The following is a description of a gene set: Human Gene Set: MODULE_13 species: Homo sapiens Genes in the cancer module 12., and this is the list of marker genes: TLE3, NPAS1, TMSB4Y, FHIT, ADGRE1, PAX8, ODF1, PPP2R5D, MEF2D, SYNCRIP, KAT7, SIM2, FMO4, M6PR, ALPG, MYOZ3, CIZ1, LYPD3, UNC119B, SLIT3, LPAR2, MAG (myelin associated glycoprotein), TCOF1, S100A5, SNX21, SLC4A3, SEMA3F, ADD2, KRT4 (keratin 4), VCY, FIG4 (FIG4 phosphoinositide 5-phosphatase), FEZ1, REL, PFDN1 (NCBI Gene Id 5201), SPC25 (SPC25 component of NDC80 kinetochore complex), IVD, DNALI1, MSC (NCBI Gene Id 9242), MMP15, ALAS2, ZBED4, KRT86, SKI, LLGL2, VASH1, DDX19A, EFNA3, AIF1, PPP6R2, MYOG, STXBP1, FBN2, DBN1 (NCBI Gene Id 1627), VPS9D1, CORT, KCNH2 (potassium voltage-gated channel subfamily H member 2), CD5L, IFIT1, RANBP2, SPEF1, UGT2B15, TBXA2R, RTN2 (NCBI Gene Id 6253), HSF4, ARC, SPART, ALDH1L1, MGP, PSD4, LAIR1, DRD3, RHBDL1, LY6G6C, RECQL5, HTR6, SRCAP, ACKR1, CSRP3, LTK, CDKN2C, CNTN2, IKBKE, LILRA4, ECE2, PDPK1, P2RX7, CLCNKA, HRG, JAG1, VSIG4, ZNF22, CD34, EMID1, PINK1, EXD2, CEP135, RPS6KB2 (NCBI Gene Id 9017), ASIC2, PTGS1, SLC13A2, INPP5D, SLC7A4, PSD, TNFRSF10C, SLC6A8, TEX261, XDH, CLIP2, DOK2, AVPR1B, TGOLN2, GRM4 (glutamate metabotropic receptor 4), USP9X, ANK1, KRT85, SIX1, CD19, SCAMP5, STARD5, PPP3CC, CYP2A6, TAFAZZIN, SH3BP1, GATA1, GAGE1, ABCC8, PDE4C, ORC1, CD33, SEMA4D, PRSS16, GTF2H3, SYNGR4, CD40, BUD23, ARHGAP4, YPEL1, B4GALT3, ETV3, KCTD17, NTSR2, AQP7, GFPT2, ZKSCAN7, CLEC11A, CYP11A1, SLC25A11, PICK1, FZR1, SLC18A3, KCND3, IFRD2, REG1A, MYO9B, GPA33, CTSC, LARGE1, NDST1 (NCBI Gene Id 3340), GPRIN2, CHRNB1, ACACA, CNKSR1, GPR161, ATP4A, AANAT, RAB8A, CCL13, IVL, FANCG, ADAM15, FUT7, RIBC2, ARSL, TRIM15, CD82, U2AF2, MDC1, ASGR2, ATP6V1B1, S1PR2, DGKA, KRT31, PLAU, TCF7, AMELX (amelogenin X-linked), LMO1, COL10A1, LRRC23, PLIN1, DEFA1, CARD10, ABHD14A, HSD11B2, SCARB1 (NCBI Gene Id 949), FLT1, SLC2A1, MXRA8, ACIN1, PSG7, IKBKG, CAD, SPRR2C, BMP10, DPT, PROC, DAPK2, TIMP3, SLC29A2, ELAVL2, ESR1, DOLK, TGFB1, MAGEA9, CRHR2, COPS6, CNOT4, HTR7, MGAT1 (alpha-1,3-mannosyl-glycoprotein 2-beta-N-acetylglucosaminyltransferase), CDK5R1 (cyclin dependent kinase 5 regulatory subunit 1), FCGR2A, CYP2C9, EFNB1, GHITM (growth hormone inducible transmembrane protein), TERF2, SULT4A1, CDK5R2, RASSF7 (Ras association domain family member 7), RAP1GAP, TUBB2A, METTL1, LGALS9, LSM4, GOLGA1, PAK4, IFT140, FOSL2, COL1A1, MYEF2, SLC5A2, BMP1, ADAMTSL2, ILRUN, RAC2, ITGA3, TM4SF5, SLC6A6, WBP4, LRCH4, KCNA5, ARVCF, C8B, SERBP1, ITSN1, CSF1, CTSG, DNAJC7, MMP11, PNMT, SIK3, TBX19, HTRA2, PLIN3, DIDO1, ARID4B, VAMP1, LY6E, TTLL12, EDEM1, CNTN1, KIF1C, UTRN (utrophin), ZSCAN12, SAC3D1, ESPL1, GLE1, HDGF, TEX28, CHST15, ANKRD12, ZNF157, ADCYAP1, ST6GALNAC4 (NCBI Gene Id 27090), RPS26, RGS9, ACKR2, GRIK5, DKK4, KCNJ4 (potassium inwardly rectifying channel subfamily J member 4), RIMS2, WNT10B, EPAS1, NEURL1, MYBPC1, LIF, LMTK2, PTPRO, CMA1, DMBT1, UCN, CHRNE, CD8B, PPM1D (NCBI Gene Id 8493), BAHD1, ASCC2, FGFR4, ITGA10, IRF5, ZBTB40, CCKAR, PBX1, ASGR1, CREBZF, LRIT1, DNAH9, CDH16, LYZL6 (lysozyme like 6), TNP1, CCDC69 (coiled-coil domain containing 69), LBP, AQP5, SDC3, F7, SLC6A9, ENTREP3, LYPLA2, SERPINA4, SLC6A11, SLC22A6, PDK4, PRPF31, TECR, NHERF2, RPA2, HAP1, ACVRL1, IQCB1, GRIN2A, SRPX, FDXR, FST, SIT1, DPF2, CRYBA4, CHST3, PRPH, HSPBP1, OTUB1, BDH1, TSPOAP1, ARHGDIG, CREB3, KIFC3, SIGMAR1, ALDOB, MTHFR, DPH2, HSD17B3 (hydroxysteroid 17-beta dehydrogenase 3), KLHL18, MMP25, PAX9, CDH4, PFKFB3, CIAPIN1, PLK1, PCDHGC3 (NCBI Gene Id 94378), GRK2, PRELID3A, PPIF, ATP1B2 (ATPase Na+/K+ transporting subunit beta 2), GJB5, POU4F1 (NCBI Gene Id 730659), PMF1, NUDT3, PITPNM1, LPXN, E2F4, OPRL1, HLA-DOB, UBE2D1, RPH3A, TRAFD1, CYP2C18 (NCBI Gene Id 1562), CPNE6, MCRS1, HTR4, KCNAB1, CRCP, ATF6B, PDGFRA, MPP2, MFN1, CALB2, PCBP3, FOSL1, COL19A1, FANCL, CD1C, SMPDL3B (NCBI Gene Id 27293), DRG2, GAD2, TACC2, PAX7, RREB1, PIGA, GJB1, TUB, KCNK3, FAT2, CTF1, SLC1A4, TPMT, CDX2, CCHCR1, DPEP1, IGHMBP2, ST14, PRRC1, MATN1, MFAP2, EPM2A, VENTX, PXN, EHD1, MYBPC2, SIX3, OCEL1, PTPN9, SLC1A6, E2F1, PGC, DENND2B, ARTN, APLP1, PCNX2, EPOR, ITGA2B, MAPK8IP1, CDK6, NRTN, DSG1, MYL2, SLC17A7, GTSE1, GPX3, CYP4B1, PIGB, ABO, MTFR1, DEFB4A, SLC6A2, ITPR2, CHIT1, RABGGTA, H6PD, DDX11, MCM2, SEZ6L, RAPGEF5, ATP6V0A2, TUBGCP2, SZT2, SCN1B, AGPAT1, MR1, H2BC17, GYPB, POLA2, ZNF143, LGR5, GPR3, CACYBP, KRT2, PIK3CB, ARPC4, DHCR7, POU6F1, ZNF592, TNXB, UBL3, CSH2, SLC30A3, HRK, TUBG1, TTLL3, DNASE1, PI3, HMOX2, TBCD, TNR, HAL, AKAP3, NPM3, PHF10, ACR, AFAP1, NR1D1, COLGALT2, RAD51D, SPN, PFKFB2, ALDOC, CFP, VPS11, NFRKB, SAR1A, ENTPD2, XRCC2, LORICRIN, MVK, PIGR, SLC6A7, TNFRSF25, TUBGCP4, RASSF1, ELAVL3, CEACAM3 (CEA cell adhesion molecule 3), CAMK2B, TAF1, CD22